Given this list of marker genes CCR7, TNF, ZP3, PARK7, FCGR1A, LTA, CD28, C3, KARS1, HLA-E, CD81, BTK, FCER1G, here is a description of the gene set: studied in species Homo sapiens Human Gene Set: GOBP_POSITIVE_REGULATION_OF_INFLAMMATORY_RESPONSE_TO_ANTIGENIC_STIMULUS Any process that activates or increases the frequency, rate, or extent of an inflammatory response to an antigenic stimulus.